Given this list of marker genes MBNL3, LY6G6C, ATP8A1, FLRT1, ZNF510, NPTX1, PLXNA4, MICAL3, OR7D2, HECTD3, ST8SIA1 (NCBI Gene Id 6489), FBXO10, GINS2, CDK19, NOA1, PTAR1, THRB (NCBI Gene Id 7068), SPRYD4, DUSP23, OR11A1, NETO2, AK9 (NCBI Gene Id 401271), SMCR8, NUCB2, HIC1, ATPAF1, CCDC157, MYORG, LAMTOR3, DSE, TNRC6B, STK36, CLEC4E, KAT6A, EDA2R, IPO13, SHPRH, RASGRP3, PML, ATP8A2, ATP11A, VPS36, COL9A2, PPFIA4, RAB9B, LMX1A, PRX, MYCT1, RGR, ABI2, here is a description of the gene set: species: Homo sapiens Genes predicted to be targets of miRBase v22 microRNA hsa-miR-6726-5p in miRDB v6.0 with MirTarget v4 prediction scores > 80 (high confidence targets). from publication Chen Y, Wang X (PMID 31504780) Human Gene Set: MIR6726_5P